The following is a description of a gene set: Human Gene Set: GOMF_RNA_POLYMERASE_III_TYPE_3_PROMOTER_SEQUENCE_SPECIFIC_DNA_BINDING Binding to a sequence of DNA that is a part of a type 3 promoter that controls transcription by RNA polymerase III (Pol III). A type 3 Pol III promoter is composed of elements upstream of the transcription start site, including a TATA box. The human U6 snRNA gene has a type 3 promoter. Type 3 Pol III promoters have not been observed in S. cerevisiae. species: Homo sapiens, and this is the list of marker genes: MTOR, SNAPC4, SNAPC3, BRF1, MAF1, BRF2